The following is a description of a gene set: Mouse Gene Set: GOBP_RNA_POLYMERASE_I_PREINITIATION_COMPLEX_ASSEMBLY The formation of a large multiprotein-DNA complex that self-assembles on gene promoter through the sequential recruitment of the general initiation factors that compose the preinitiation complex (PIC) (which includes including UBF, SL1, RRN3 and TBP in human). The PIC engages RNA polymerase I on its DNA template strand and sparks polymerization of the first few RNA nucleotides. species: Mus musculus, and this is the list of marker genes: Taf1c, Rrn3, Taf1b, Polr1e, Tbp, Smarcb1